Given this list of marker genes Dna2, Rmi2, Blm, Slx4, Slx1b (NCBI Gene Id 75764), Mus81, Eme2, Gen1, Bard1, Atm, Xrcc2, Brca1, Eme1, Rbbp8, Rad51ap1, Palb2, Exo1, Rad50, Brip1, Fignl1, Firrm, Brca2, Kat5, Rad51d, Rad51b, Mre11a, Spidr, Xrcc3, Rad51c, Rad51, Top3a, Wrn, Nbn, Rmi1, here is a description of the gene set: Resolution of D-Loop Structures species: Mus musculus Mouse Gene Set: REACTOME_RESOLUTION_OF_D_LOOP_STRUCTURES